The following is a description of a gene set: This event has been computationally inferred from an event that has been demonstrated in another species.<p>The inference is based on the homology mapping from PANTHER. Briefly, reactions for which all involved PhysicalEntities (in input, output and catalyst) have a mapped orthologue/paralogue (for complexes at least 75% of components must have a mapping) are inferred to the other species. Reactome Pathway: SUMOylation of ubiquitinylation proteins part of: SUMO E3 ligases SUMOylate target proteins electronically inferred by orthology from the curated human pathway species: Mus musculus, and this is the list of marker genes: Pias4, Nup85, Ndc1, Nup42, Sumo1, Nup93, Nup210, Trim27, Nup205, Nup133 (nucleoporin 133), Nup54, Aaas, Rae1, Seh1l, Nup155, Nup58, Vhl